The following is a description of a gene set: part of: Neurotransmitter release cycle Reactome Pathway: Glutamate Neurotransmitter Release Cycle electronically inferred by orthology from the curated human pathway This event has been computationally inferred from an event that has been demonstrated in another species.<p>The inference is based on the homology mapping from PANTHER. Briefly, reactions for which all involved PhysicalEntities (in input, output and catalyst) have a mapped orthologue/paralogue (for complexes at least 75% of components must have a mapping) are inferred to the other species. studied in species Mus musculus, and this is the list of marker genes: Slc1a7, Cplx1, Syt1, Vamp2, Gls2, Slc38a2, Slc1a6, Stx1a, Ppfia3, Slc17a7, Ppfia2, Rab3a, Tspoap1